The following is a description of a gene set: species: Mus musculus The chemical reactions and pathways resulting in the breakdown of a fatty-acyl-CoA, any derivative of coenzyme A in which the sulfhydryl group is in thiolester linkage with a fatty-acyl group. Mouse Gene Set: GOBP_FATTY_ACYL_COA_CATABOLIC_PROCESS, and this is the list of marker genes: Nudt19, Fitm2, Acot2, Nudt7, Nudt8, Acot7, Abcd1